The following is a description of a gene set: electronically inferred by orthology from the curated human pathway This event has been computationally inferred from an event that has been demonstrated in another species.<p>The inference is based on the homology mapping from PANTHER. Briefly, reactions for which all involved PhysicalEntities (in input, output and catalyst) have a mapped orthologue/paralogue (for complexes at least 75% of components must have a mapping) are inferred to the other species. Reactome Pathway: PI5P Regulates TP53 Acetylation species: Mus musculus part of: Regulation of TP53 Activity through Acetylation, and this is the list of marker genes: Trp53, Map2k6, Pip4p1, Ep300, Pip4k2c, Ing2